Given this list of marker genes YEATS4, CTSL, ANP32A, H2BC1, ING1, SSRP1, WDR5B, SMARCC1, KDM1B, PHF13, TONSL, ZNF689, ZZEF1 (NCBI Gene Id 80238), CBX2, HAT1, PWWP2A, PHF19, CHD2, BAZ1B, NAP1L2, BPTF, TSPYL6, NAP1L4, DNAJC9, RBBP5, TSPY2, CHD7, PHF8, SRCAP, SCML1, CDYL, PHF14, ZMYND11, CXXC1, TSPYL5, SMARCA4, KMT2E, SMARCA5, CHD4, CDYL2, SART3, MLLT10 (NCBI Gene Id 8028), USP49, GLYR1, ING2, SPTY2D1, PTMS, ZCWPW2, SCML4, SNCA, WDR5, L3MBTL1, MCM2, VPS72, FAM156A, SAMD7, PHC2, FH, TSPY8 (testis specific protein Y-linked 8), NBN, BRD9, TP53BP1, ZZZ3, NASP, CHD3, SFMBT1, UHRF2, GRWD1, SPIN2B, SAP30L, L3MBTL3 (NCBI Gene Id 84456), MLLT6, PRMT6, PTMA, CBX1, AIRE, PYGO2, ING3, EED, TSPYL2, NCAPD3, RNF8 (ring finger protein 8), HINFP, TNKS, PARP9, PHF1, SPIN3, BAZ2A, AGER, DEK, CKS1B, BRD2, USP51, BRD4, WRAP53, RCC1, SETSIP, TSPY1, NPM3, UIMC1, KMT5C, BRDT, MTF2, COPRS, SETD5, TBL1XR1, RSF1, SGF29, BCAS3, BRD7 (NCBI Gene Id 29117), CHD6, FAM156B, TRIM24 (tripartite motif containing 24), SBNO2, CHAF1B, SPIN4, ANP32E, SPIN1, UHRF1, SFMBT2, SCMH1 (NCBI Gene Id 22955), PHC1, VRK1, USP16, SIRT1, TSPY10 (NCBI Gene Id 124909093), NAP1L3, IPO9, BRD3, NPM1, ZCWPW1, KDM5A, MPHOSPH8, L3MBTL4, USP3, NAP1L1, AASS, TSPY4, CKS2 (NCBI Gene Id 1164), DNAJC2, CTCFL, PSME4, EZH1, PKN1, CBX3, ASF1A, TAF1L, HIRA, TSPYL1, ASF1B, SUPT6H, SPHK2, TBL1X, PHIP, YEATS2, HDAC2, RBBP4, MCM3AP, HDAC4 (NCBI Gene Id 9759), ING5, ZNHIT1, KDM5B, PHF6, MLLT1, MORC4, WDTC1, STPG4 (NCBI Gene Id 285051), CHD5, APBB1, ING4, EZH2, PRKCB, TSPY3, NOC2L, JAK2, DPPA3 (NCBI Gene Id 359787), MYSM1, NCAPD2, RESF1, CHD1, HJURP, ZMYND8, IPO7, CBX6, RBBP7, STAT1, NPM2, SCML2, MORC3, SMARCA2, ATAD2, SAMD11, RNF20 (NCBI Gene Id 56254), H1-9P, DAXX, ANP32CP, SPIN2A, RAG1, PIH1D1, L3MBTL2, PRMT7, ATRX, DTX3L, INO80, MLLT3, TSPY9, SET, SBNO1, HPF1, RNF168, ATAD2B, ANP32B, MBTD1, CHD8, TSPYL4, RRP8, SMARCC2, PHC3, CBX8, H2AX, APLF, CBX5, here is a description of the gene set: Human Gene Set: GOMF_HISTONE_BINDING studied in species Homo sapiens Binding to a histone, any of a group of water-soluble proteins found in association with the DNA of eukaryotic or archaeal chromosomes. They are involved in the condensation and coiling of chromosomes during cell division and have also been implicated in gene regulation and DNA replication. They may be chemically modified (methylated, acetlyated and others) to regulate gene transcription.